Given this list of marker genes ENC1, MARK1, TTC33, LAPTM5, LINC03103, FASTKD2, KCNMA1, RAB3A, EID1, MARF1, TPRG1L, LUZP2, ZFHX3, ARL8B, CCDC141, PAX3, TIGAR, POLR3G, CDK8, DIPK2A, PEG10, SCAF8, GSPT1, WLS, UBE2D3, MARCHF6, CES5A, PDCD6IP, SREK1, LPIN2, PLEKHF2, EPPK1, TRMT61A, ZNF493, RCAN1, TDG, ACER3, BNC2, BCAP31, ZZZ3, ARHGAP44, SRP72, PRUNE2, HSPA4, KPNA1, CDK14, UBAP2, HS3ST4, HIF1A, PRMT3, CCDC117, C1R, ZFR, SI (sucrase-isomaltase), GAD2, SP4, DOP1A, IAH1, SRI, PTRHD1, DTD1, SHC3, ATP11A, ERO1B, CCDC144A, SLC30A10, RAG1, SETDB2, SOX6, NUDT12, SLC39A6, BPNT2 (NCBI Gene Id 54928), ARHGAP5, MINPP1, CEP135, DEFB132, TENM1, BCL2L11, TAF9, here is a description of the gene set: Human Gene Set: MIR549A_3P Genes predicted to be targets of miRBase v22 microRNA hsa-miR-549a-3p in miRDB v6.0 with MirTarget v4 prediction scores > 80 (high confidence targets). from publication Chen Y, Wang X (PMID 31504780) studied in species Homo sapiens